The following is a description of a gene set: Abnormality of facial soft tissue Human Gene Set: HP_ABNORMALITY_OF_FACIAL_SOFT_TISSUE species: Homo sapiens, and this is the list of marker genes: LPIN1, TRIM32 (tripartite motif containing 32), CRYAB, SDHC, CDH11, TERT, DPYSL5, COL12A1, ATP1A2, SNUPN, TP63, LHX3, HAVCR2, MSX1, MYMX, PEX19, SIX5, HLA-DPA1, POU4F1, NPHS1, FKBP6, PLCE1, MTM1, SLC26A2, MT-TN, ESCO2, EMP2, CC2D1A, F12, CACNA1A, OPA1, PEX26, SYNE1 (NCBI Gene Id 85448), NEB, PEX16, TNNT1, TPM3, CCDC22, GBA1, PEX12, PTPN22, DNAJC30, MT-CO3, PRKCG, ITGB4, SLC19A3, DNAJC6, TWNK, TNFSF11, DNMT3B, CAPN3, ADNP, MUSK, TNNC2 (NCBI Gene Id 7125), TPP2, PEX2, ANLN, DDHD2, MYL2, DCTN1, SLC5A5, SERPING1, SATB2, DAAM2, PMS1, CHD7, XRCC2, SNX14, ITGA7, CLCF1, SLC26A4, DLL4, ABCD1, DPAGT1, MTMR2, ACTN2, MEGF10, CHAT, RNASEH1, PABPN1, ABCA1, KCNK4, XPNPEP2, TXNL4A, DUOX2, STRADA, MYO9A, SDHB (succinate dehydrogenase complex iron sulfur subunit B), SUPT16H, CHRND, APOL1, GLI3, MYL1, ZBTB11, ALG2, PEX13, ANGPT1, CHAMP1, RILPL1, VPS35L, REV3L, MYOF (NCBI Gene Id 26509), GAN, KY, PLEC, CHKB, SLC6A3, AP4B1, DUX4L1, TSHB, SOST, UNC80, GAA, SLC1A3, COL1A1, MYOT, ALS2, BMS1, PCGF2, KNG1, WT1, LRP5, RBM8A, SLC39A14, JAM2, POU3F3, LRRK2, KDM4B, SYNJ1, GRIA3, CLTC, IRF2BPL, KRAS, UBE2T, COL5A1, RYR1, NLRP1, SPTBN4, FLNC, TMEM270, FKRP, IFNG, PRDX3, UBA1, CACNA1S, NGLY1, KNSTRN, NKX2-1, SLC25A21, KAT6A, TBL2, DHX30, PPP2R2B, POMT2, SMCHD1, SPR, DYNC1H1, PLAA, ACTB, AK9, CIDEC, ANTXR1, PTDSS1, PI4KA, COQ8B, LRP4, ACTG1, ERCC6, GDAP1, ADSS1, CLCN7, PTRH2, YARS1 (tyrosyl-tRNA synthetase 1), POR, PLG, DUOXA2, SCO2, COL4A1, COL5A2, LRIF1, NEFL, COLQ, SMO, PIK3CA, NECTIN1, KLHL41 (kelch like family member 41), MED12L, CADM3, TREX1, NARS2, KCNJ6, GPC3, PSMB4, ADA2, MSTO1, SUFU, MEN1, CHRNE, AMER1, GTF2IRD2, MYD88, AP4M1, TTN, NFU1, ATP1A3, GPR101, DNAJC13, SHMT2, AIP, SLC25A4, MT-CO1, NCF1, RRM1, MYPN, PPP2R5D, TUBB3, FBXO11, CD2AP, VPS13B, DSE, SMARCE1, RAPSN, TGFB1 (NCBI Gene Id 7040), ZNHIT3, SRRM2, SOX18, SUCLA2, BUD23, NPHS2, VAMP1, LGI3, TGFBI, ANAPC1, HESX1, SIX1, RASA1, NKX2-5 (NCBI Gene Id 1482), PROP1, GAPVD1, KIF1B, PEX10, DNM2, LARGE1, ALG14, SPEG, KLLN, CRLF1, YY1, EBF3, GNA14, GNPTAB, LRP12, ANXA11, DBH, POLG, USF3, GMPPB, DMPK, CRB2, PPP1CB, LMNA, PAX8, KRT17, STAG2, RRM2B, ZC4H2, MT-TE, CTLA4, LAMA2, SYT2, GSN, GNAQ, LAMB2, PURA, SLC30A9, BAP1, FKTN, KCNK9, PUF60 (NCBI Gene Id 22827), SLC52A2, CHRNA1, TSHR, SEMA3E, PEX14, VPS37D, STAC3, WASHC5, MAP3K20, CD96, BAG3, SLC5A7, ALB, GIGYF2, NRAS, RNU4-2, NUP85, AGRN, SLC18A2, CNBP, PDGFB, COX6A2, PPARG, ATP13A2, DOK7, ANO5, PLA2G6, MSH2, MAN2B1, SCN1A, SPTBN1, DES, SLC52A3, XYLT2, SQSTM1, SLC35C1, POLR3A, COL6A2, SRPX2, SH3TC2, MAGI2, POMT1, POLG2, TFAP2A, PEX1, NUTM2B-AS1, LTBP4, CCBE1, TRPC6, STX1A, KBTBD13, MSH6, ACTN4, NUP107, TOR1A, KLHL40, BTNL2, OSTM1, PEX3, POGZ (pogo transposable element derived with ZNF domain), CHCHD10, RIN2, LHX4, SLC25A1, AP4E1, BAZ1B, HACD1 (NCBI Gene Id 9200), PRTN3, ATXN1, ARHGDIA, AMPD2, SLC29A3, KCTD1, ACADS, ZMPSTE24, CRPPA, CHRNB1, HLA-DPB1, CHRNG, MYH7, ADAMTS2, FBXO7, PLCD1, LIMK1, MYMK, MTRFR, EIF4H, IGSF3, COL13A1, SF3B2, NUP93, ADCY6, CLIP2, VPS35, HS3ST6, POMP, NOD2, SLC18A3, SCN4A, PIK3CD, FOXG1, TBC1D8B, RFC2, PIEZO1, SGCD, RECQL4, NF2, SNCA, DUX4, ATP6AP2, PSPH, MGAT2, DNM1L, SBF2, GFPT1, PRRT2, POU1F1, EPHB4, ARHGAP24, EYA1, HERC1, TNFRSF1A, FRG1, EIF4G1 (eukaryotic translation initiation factor 4 gamma 1), PEX5, FRMD4A, SHANK3, CNTNAP1, RYR3, FTL, PTEN, OBSCN, MTMR14, GJC2, SNX10, NUP133, COL4A3, AP4S1, ELN, TPM2, MPZ, TGFBR2, HK1, SEC23B, ASXL1, GNE, ADCY5, GPC4, PODXL, ITPR1, VCP, SALL4, SRD5A3, PLXND1, KMT2D, SLC25A42, SETBP1, TCIRG1, PSMB8, EPCAM, MB, FOXE1, SLC12A6, TG, PMS2, TK2, TRAF7, ACTA1, AKT1, LMOD3, DNAJB6, ATCAY, PNPT1 (NCBI Gene Id 87178), HLA-DRB1, NUP37, GLE1, GTF2IRD1, SET, GIPC1, ANKH, BIN1, TRPM3, TPO, SUMF1, LMNB2, CAMTA1, PAX2, CFL2, MLH1, SPTBN2, TECPR2 (NCBI Gene Id 9895), NOTCH2NLC, CAMK2G, PEX11B, RBMX, SNAP25 (synaptosome associated protein 25), SURF1 (SURF1 cytochrome c oxidase assembly factor), JAG2 (jagged canonical Notch ligand 2), ANKFY1, NUP205, ERCC8, YME1L1, HRAS, UBA2, DHCR7, RAB11B, GJA1, LYN, COL6A1, SDHD, SLC30A10, METTL27, ADGRG1, MGME1, TSC2, PPP2R1A, ZMIZ1, TUBB6, PAX7, GTF2I, KDM5C, TSC1, ASAH1, TRPV4, NEU1, MYO1E, TET3, IYD, EFEMP1, BICRA, INF2, MECP2 (NCBI Gene Id 8274), NUP160, PTPRO, PEX6, SELENON, IRF6, KPTN, SMARCB1, HOXB1